Given this list of marker genes Adk, Gtf2ird1, Gtf2ird2, Atp2a2, Tead1 (NCBI Gene Id 70301), Mtor, Myh7, Camk2d, Gdf1, Ptk2, Casq1, Selenon, Tnnc1, Trpc3, Fdps, Trip10, Ctdp1, Nfatc3, Ppp3ca, Tnni1, Agt, Rock2, Pde9a, Mef2c, Adrb1, Nos3, Klf4, Myog, Pde5a, Rps6kb1, Rbm10, Adra1a, Acacb, Bmp10, Prkca, Fbxo32, Lmcd1, Adcy10, Yy1, Scn5a, Akap1, Trim63, Tnfrsf1b, Tnfrsf1a, Cmya5, Ndufs4, Srl, Kcnn4, Nr4a3, Hdac4 (NCBI Gene Id 208727), Pparg, Ppara, Twf1, Tomm70a, Jarid2 (jumonji and AT-rich interaction domain containing 2), Gsn, Ep300, Rgs4, Becn1, Tnnt1, Nfatc1, Ccn4, Foxo1 (NCBI Gene Id 99758), Mtmr4, Ddx39b, Mef2a (NCBI Gene Id 320979), Edn1, Dmd, Igfbp5, Hand2, Cav3, Mlip, Errfi1, Atp2b4, Lmna, Slc9a1, Prkag3, G6pd2, Foxp1, Sgca, Smad3, Parp1, Rgs2, Actn3, Glrx3, Nol3 (NCBI Gene Id 78688), Aif1, Smad4, P2rx4, Gsk3b, Pin1rt1, Stub1, Pi16, Nr3c1, Hamp, Igf1, Pak1, Dag1, Parp2, Rock1, Ece1, Pin1, Gsk3a, Foxo3, Mymk, Cdk9, Sirt1, Hamp2, Notch1, Gata5, G6pdx, Slc25a4, Mtpn, Akap6, Zfp418, Oga, here is a description of the gene set: Any process that modulates the frequency, rate or extent of muscle adaptation. studied in species Mus musculus Mouse Gene Set: GOBP_REGULATION_OF_MUSCLE_ADAPTATION